Given this list of marker genes PTPRR, NMT2, LDB2, POP1, RABGAP1L, ID2, NUP155, MID1, PAFAH1B1, KCNK2, ATXN1, HMGCL, SIPA1L1, TRIM2, H4C12, DENND3, ZMYND8, ZNF623, MAP3K5, SPRY1, BAG2, MAST4, CBR4, CMA1, PUM3, U2SURP, ZNF415, ZMIZ1, RUNX1, ATP12A, CDKN3, SERPINE1, FHL2, GZMK, UBE2C, RBMS1P1, SPAG5, SRSF3, PAIP1, SLF2, VWA5A, UGCG, ASXL1, CXCL12, TRAK1 (NCBI Gene Id 22906), PLCE1 (phospholipase C epsilon 1), NREP, WDR45, MTCL1, AKT3, FGF7, TSPAN5, TUBA1A, PTOV1-AS2 (NCBI Gene Id 101928378), MYH8, PDGFRA, ZNF516, FLRT2, THBS2, DLC1 (DLC1 Rho GTPase activating protein), SSH1, SERPINB1, LRRC17, OGA, DENND2B, NR1D2, CILK1, DHRS3, INPP5B, SNRPA, KIAA1549L, PRIM2, ECM2, HNRNPH3, SDC2, UBR5 (ubiquitin protein ligase E3 component n-recognin 5), IGF2, RUNX1T1, SLC12A1, STK17A, TBC1D8, CRYBG1, ACSL3, ZIC1, PMP22, FYN, FGF5, RIN2, MAMLD1, ERCC2, RIN1, VPS13B, EXOC6B, GABBR2, DAB2, APEX1, GLI3 (GLI family zinc finger 3), TTLL1, TBX5, PTP4A1, here is a description of the gene set: Genes down-regulated in primary fibroblast cell culture after infection with HCMV (AD169 strain) at 12 h time point that were not down-regulated at the previous time point, 10 h. species: Homo sapiens The effect of human cytomegalovirus (HCMV) infection on cellular mRNA accumulation was analyzed by gene chip technology. During a 48-h time course after infection of human diploid fibroblasts, 1,425 cellular mRNAs were found to be up-regulated or down-regulated by threefold or greater in at least two consecutive time points. Several classes of genes were prominently affected, including interferon response genes, cell cycle regulators, apoptosis regulators, inflammatory pathway genes, and immune regulators. The number of mRNAs that were up-regulated or down-regulated were roughly equal over the complete time course. However, for the first 8 h after infection, the number of up-regulated mRNAs was significantly less than the number of down-regulated mRNAs. By analyzing the mRNA expression profile of cells infected in the presence of cycloheximide, it was found that a minimum of 25 mRNAs were modulated by HCMV in the absence of protein synthesis. These included mRNAs encoded by a small number of interferon-responsive genes, as well as beta interferon itself. Cellular mRNA levels in cytomegalovirus-infected cells were compared to the levels in cells infected with UV-inactivated virus. The inactivated virus caused the up-regulation of a much greater number of mRNAs, many of which encoded proteins with antiviral roles, such as interferon-responsive genes and proinflammatory cytokines. These data argue that one or more newly synthesized viral gene products block the induction of antiviral pathways that are triggered by HCMV binding and entry. Human Gene Set: BROWNE_HCMV_INFECTION_12HR_DN from publication Browne EP, Wing B, Coleman D, Shenk T (PMID 11711622)